Given this list of marker genes SERPINF2, F13A1, ACTN4, TOR4A, F8, ISLR, VEGFD, VEGFA, F5 (NCBI Gene Id 98271), VWF, MAGED2, GTPBP2, ACTN2, EGF, TEX264, TGFB3, NHLRC2, PDGFB, FN1, SPARC, TMSB4X, TGFB2, A1BG, AHSG, PCYOX1L, QSOX1, ORM1, VEGFB, FGA, IGF2, ORM2, TGFB1, APOOL, FGB, MMRN1, APP, PLG, SERPINA1, OLA1, THBS1, A2M, VTI1B, PF4, FGG, ALDOA, SERPINE1, IGF1, GAS6, SERPING1, ACTN1, SRGN, TIMP1, VEGFC, LEFTY2, PPBP, FERMT3, PROS1, ALB, PDGFA, CYRIB, HGF, CLU, SERPINA3, HRG, SCCPDH (saccharopine dehydrogenase (putative)), KNG1, CFD, here is a description of the gene set: Human Gene Set: GOCC_PLATELET_ALPHA_GRANULE_LUMEN species: Homo sapiens The volume enclosed by the membrane of the platelet alpha granule.